The following is a description of a gene set: Mouse Gene Set: GOMF_CALCIUM_SODIUM_ANTIPORTER_ACTIVITY Enables the transfer of a solute or solutes from one side of a membrane to the other according to the reaction: Ca2+(in) + Na+(out) = Ca2+(out) + Na+(in). studied in species Mus musculus, and this is the list of marker genes: Slc8a1, Slc24a1, Slc8b1, Slc24a5, Slc8a2, Slc24a3, Slc24a2, Slc8a3, Slc24a4